Given this list of marker genes Prkar1a, Cul9, Myc, Ctnnb1, Rb1, Men1, Cdkn1b, here is a description of the gene set: Mouse Gene Set: MP_INCREASED_PITUITARY_GLAND_TUMOR_INCIDENCE from publication Motenko H, Neuhauser SB, O'Keefe M, Richardson JE (PMID 26092688) Mouse genes annotated to increased pituitary gland tumor incidence (MP:0010320) retrieved from the Mouse Genome Informatics database via MouseMine studied in species Mus musculus